Given this list of marker genes GTSE1, NUFIP2, PAIP2, TMEM156, GAPVD1, TAF2, SP1, PAK2, FUBP3, TRAM1, USP22, VCPIP1, ANKRD17, PRP4K, DNAJA3, CSNK1A1, H2BC12, FUNDC2, LNPEP, ANKRD20A1, MBNL1, SLC16A1, CENPT, PUM2 (NCBI Gene Id 23369), G3BP2, SCYL2, TBC1D14, USP25, LTN1, FEM1B, TRIM23, AVL9, IFT46, CMPK1, RPE, INTS8, POLR2M, DR1, NFYA, CILK1, CLASP2, SMAD5, MAPK1, ZNF639, ABCB7, EPS15, CDKN2A-AS1, SMC5, THOC2, IL21R, RAVER1 (ribonucleoprotein, PTB binding 1), TENT4A, MC1R, MIB1, ZMYM4, here is a description of the gene set: species: Homo sapiens Human Gene Set: MODULE_277 Genes in the cancer module 277.